The following is a description of a gene set: Relaxin receptors studied in species Mus musculus Mouse Gene Set: REACTOME_RELAXIN_RECEPTORS, and this is the list of marker genes: Rxfp3, Rxfp2, Insl3, Rxfp1, Rxfp4, Rln3, Insl5, Rln1 (relaxin 1)